Given this list of marker genes LEF1, LILRA5, TNFRSF21, IFNL1, SCGB1A1, ARG2, IFNA2, here is a description of the gene set: Any process that stops, prevents, or reduces the frequency, rate, or extent of interleukin-13 production. species: Homo sapiens Human Gene Set: GOBP_NEGATIVE_REGULATION_OF_INTERLEUKIN_13_PRODUCTION